Given this list of marker genes MIR146A, LEF1, FGFR2, PTH, PLK2, here is a description of the gene set: species: Homo sapiens Human Gene Set: GOBP_REGULATION_OF_APOPTOTIC_PROCESS_IN_BONE_MARROW_CELL Any process that modulates the occurrence or rate of cell death by apoptotic process in the bone marrow.